Given this list of marker genes CRIPT, NLGN1, LRRC4B, SHANK3, LRRTM2, CSMD2 (CUB and Sushi multiple domains 2), ADGRL3, FGFR1, SEMA4A (semaphorin 4A), WNT5A, LRRC4, LRFN1, PTPN13, ABI3, PRICKLE1, NRXN1, CBLN1, ADGRL2, C1QL2, CLSTN3, GRID2, NPTN (neuroplastin), PTK2B, NRXN2, C1QL3, PLXNB2, SRGAP2C, NTRK3, NPTX1, SLITRK3, IL1RAP, NLGN2, WNT7A, SRGAP2, PTEN, PTPRD, RELN, ZDHHC12, LATS1, PTPRS, LRFN4, CASKIN1, VSTM5, here is a description of the gene set: The aggregation, arrangement and bonding together of a set of components to form an excitatory synapse. studied in species Homo sapiens Human Gene Set: GOBP_EXCITATORY_SYNAPSE_ASSEMBLY